Given this list of marker genes NEDD4 (NEDD4 E3 ubiquitin protein ligase), RBPJ, ACVR1, SOX9, ISL1, SNAI2, ACVRL1, ERBB3, BMPR2, MSX2, TBX5, TGFBR2, DCHS1, BMP4, FGF8, GATA4, MDM2, BMP5, ROBO1, RBM24, FOXF1, HEY2, JAG1, ENG, BMP2, DKK1, BMP7, TBX3, SMAD2, CPLANE2, NOS3, TGFB2, ADAMTS5, TGFBR1, HEYL, NOG, MDM4, ROBO2, SMAD4 (NCBI Gene Id 4089), BMPR1A, TMEM100, CITED2, TBX2, HEY1, TBX20, APC, SNAI1, TGFB1 (transforming growth factor beta 1), GATA5, TGFB3 (transforming growth factor beta 3), NOTCH1, TWIST1, APLNR, CRELD1, MSX1, here is a description of the gene set: Human Gene Set: GOBP_ENDOCARDIAL_CUSHION_DEVELOPMENT species: Homo sapiens The progression of a cardiac cushion over time, from its initial formation to the mature structure. The endocardial cushion is a specialized region of mesenchymal cells that will give rise to the heart septa and valves.